Given this list of marker genes TERC, TERT, DOCK2, SFTPA1 (NCBI Gene Id 653509), SFTPB, HCK, STAT3, ABCA3, STAT5B, IL2RB, PLCG2, RAG1, TINF2, SFTPC, SMPD1, HLA-DPB1, FOXP3, here is a description of the gene set: Interstitial pneumonitis studied in species Homo sapiens Human Gene Set: HP_INTERSTITIAL_PNEUMONITIS